Given this list of marker genes LAMA1, CYP1B1, COL4A1, CLIC4, NDP, FZD4, ARHGEF15, RHOJ, NRP1, LRP5, here is a description of the gene set: species: Homo sapiens The process in which the vasculature of the retina is generated and organized. Human Gene Set: GOBP_RETINA_VASCULATURE_MORPHOGENESIS_IN_CAMERA_TYPE_EYE